Given this list of marker genes TMED10, APH1A, PSEN2, NCSTN, PSENEN, PSEN1, APH1B, here is a description of the gene set: species: Homo sapiens A protein complex that has aspartic-type endopeptidase activity and contains a presenilin catalytic subunit (either PSEN1 or PSEN2), an APH1 subunit (multiple genes and splice variants exist), nicastrin (NCT), and presenilin enhancer (aka PEN-2 or Psenen), as the core complex. Variants of the complex with different subunit compositions differ in localization and specific substrates. Additionally, variants of the complex exist that contain a additional regulatory subunit as well as the four core subunits; known regulatory subunits include gamma-secretase-activating protein (aka gSAP), TMP1 (aka TMED10), and CD147 antigen (aka basigin). Gamma-secretase cleaves type I transmembrane protein substrates, including the cell surface receptor Notch and the amyloid-beta precursor protein. Human Gene Set: GOCC_GAMMA_SECRETASE_COMPLEX